The following is a description of a gene set: Mouse Gene Set: REACTOME_HSP90_CHAPERONE_CYCLE_FOR_STEROID_HORMONE_RECEPTORS_SHR_IN_THE_PRESENCE_OF_LIGAND HSP90 chaperone cycle for steroid hormone receptors (SHR) in the presence of ligand studied in species Mus musculus, and this is the list of marker genes: Dctn6, Capzb, Dync1i1, Capza2, Dync1h1, Dync1i2, Tuba1b, Tubb4b, Dctn4, Dctn5, Actr1a, Tubb4a, Dnaja2, Dctn1 (dynactin 1), Fkbp4, Nr3c1, Tubb2b, Tubal3, Hsp90ab1, Dnajb1, Dync1li1, Hspa1l, Hspa1b, Tubb3, Fkbp5, Dynll1, Tuba3b, Actr10, Tuba4a, Dctn2, Ptges3, Ar, Tuba8, Tuba1c, Tubb1, Hsp90aa1, Tuba3a, Capza3, Dync1li2, Pgr, Stip1, Tuba1a, Tubb2a, Tubb6, Hspa8, Dnaja1, Hspa2, Hspa1a, Dctn3, Dynll2, Nr3c2, Dnaja4